Given this list of marker genes Dctn1, Cep128, Ccdc68, Ccdc61, Cntrl, Nin, Ccdc120, Cep170, here is a description of the gene set: A protein complex which assembles on the mother centriole during cilium formation, adjacent and proximal to a centriolar distal appendage. In human, it contains ODF2, CNTRL, NIN, CCDC120c and CCDC68. Mouse Gene Set: GOCC_CENTRIOLAR_SUBDISTAL_APPENDAGE studied in species Mus musculus